The following is a description of a gene set: species: Mus musculus A stably positioned site of clathrin adjacent and physically attached to the postsynaptic specialization, which is the site of endocytosis of post-synaptic proteins. Mouse Gene Set: GOCC_POSTSYNAPTIC_ENDOCYTIC_ZONE, and this is the list of marker genes: Rab5a, Cltc, Fcho1, Dnm3, Clta, Pick1, Caly, Ap2a1, Rnf216, Hip1r, Sh3glb2